Given this list of marker genes ZNF454, TASOR2, ZEB2, ENY2, NUDCD2, ZNF33A, TMEM68, PPM1B, ASAP2, RP2, KIF1B, SIRT1, SNRNP40, RBM11, GLRB, ATP11C, ZNF57, ANKS1B, CLEC12A, BTG2, MGARP, TRIB2, CBLB, CNKSR3, SP3, ATF2, YPEL4, EVI5, AGFG1, SMAD7, PDE4D, LEKR1, KCNMA1, TMEM67, PLAC8, DCUN1D4, TMEFF2 (transmembrane protein with EGF like and two follistatin like domains 2), STYX, TEAD1, RLN1, ADGRL2, REPS2, CRBN, MAGI2, ADAMTS5, ABTB2, MOB1B, CARNMT1, ANXA4, NLK, PDE10A, SNX6, CDH8, PPP4R4, SEPTIN8, TXLNG, NEK4, ATL3, MTMR12, CALCOCO1 (NCBI Gene Id 57658), TUT7, RPRD1A, APLP2, STXBP3, CNR1, SNX2, PUM2, PNPLA4, STIM2 (stromal interaction molecule 2), CEP192 (centrosomal protein 192), RNF217, PON3, ATP8B1, TNPO1, GRIA4, ZNF281, CAMSAP1, PDZD2, ZNF780A, VTI1B, ST6GAL2, COBL, LRRTM2, SEMA3C, LRRCC1, ZC3H7A, CHKA, DYRK1A, ANKRD50, ZCCHC2, PPM1A, USP34, PRKAA1, KIAA1217, GPM6A, NTF3, ILRUN, LRCH1, AZIN1, MTMR10, APPL1, here is a description of the gene set: Genes predicted to be targets of miRBase v22 microRNA hsa-miR-154-3p in miRDB v6.0 with MirTarget v4 prediction scores > 80 (high confidence targets). studied in species Homo sapiens Human Gene Set: MIR154_3P from publication Chen Y, Wang X (PMID 31504780)